The following is a description of a gene set: species: Mus musculus Mouse Gene Set: GOBP_DEVELOPMENTAL_PROCESS_INVOLVED_IN_REPRODUCTION A developmental process in which a progressive change in the state of some part of an organism, germline or somatic, specifically contributes to its ability to form offspring., and this is the list of marker genes: Pygo1, Dmrtc2, Amhr2, Zdbf2, Cetn2, Kdm3a, Lhb, Mgat4d, Armc12, Cfap119, Sun1, D1Pas1, Csmd1, Mir96, Ddx4, Jam2, Igf1, 3830403N18Rik, Dmc1, Safb2, Tnfaip6, Tex11, Shcbp1l, Txnrd3, Ccdc136, Airn, Nme5, Patz1 (NCBI Gene Id 80645), Cadm1, Abhd2, Mertk, Schip1, Marf1, Syne1, Kash5, Kat8, Septin6, Zfp628, Alkbh5, Wnt4, Zmynd15, Pafah1b1, Nanos1, Adam15, Mir34c, Myh9, Siah1a, Washc1, Cxcr4, Galnt3 (NCBI Gene Id 620893), Pdilt, Adam4, Spo11, Dnmt3b, Tsix, Tgfbr1, Prdx4, Usp26, Catspere2, Tbc1d20, Ptgs2, Acrbp, Tpgs1, Prss42, Dach1, Adam24, Chd5, Axl, Adam6a, Gli1, Aff4, Rbmyf9, Sprr2d, Junb (NCBI Gene Id 16477), Ldoc1 (NCBI Gene Id 434784), Prlr (NCBI Gene Id 19117), Npr2, Fkbp6, Ar, Tcp11, Tbata, Cyp19a1, Wdr19, H19, Bbs2, Adamts1, Gm1140, Mir124a-1hg, Irf2bpl, Stk4, Tmem119, Gata6, Btbd35f1, Dmrta2, Sass6, Tlr9, Nlrp14, Ccna1, Scmh1, Xlr4b, Slirp, Gjb2, Prkaca, Tesk2, Nanog, Spag6 (NCBI Gene Id 381350), Bbof1 (NCBI Gene Id 72873), Brip1, Cyp1b1, Parp11, Hfm1, Tmem203, Akap4, Foxa3, Rbx1-ps, Nek1, Adam18 (a disintegrin and metallopeptidase domain 18), Zar1l, Lhx9, Zmynd12, Adam32, Vegfa, Rps6ka2, Iftap (NCBI Gene Id 68170), Mas1, Ccdc87, Mir135a-2, Prss44, Col6a1, Pgam2, Pank2, Sgpl1, Abcb1a, Dmrta1, Tssk2, Mir471, Tspan8, Gdf7, Scx, Ptgis, Yif1b, Txndc2, Tiparp, Btg1, Lamp1, Pax5, A2m, Brme1, Gm20911, Svs3a, Wipf3, Nanos2, Fgfr2, Rec114, Hnf1a, Rad23b, Oosp2 (NCBI Gene Id 225922), Gm1993, Cd44, Cfap43, Src (NCBI Gene Id 99351), Rimbp3, Tsga8, Lhfpl2, Spata6l, Xrn2, Dzip1, Cylc1, Vipas39, Bltp1, Gata3, Sema3a, Spint2, Sirt2 (NCBI Gene Id 80489), Lgr5, Cit, Fbxo5, Gm10488, Nipbl, Tfpt, Oca2, Mns1, Gm28510, Plg, Spdya, Frey1, Cbl, Catsper3, Stau1 (NCBI Gene Id 99402), Ercc1, Slc26a8, Sstr2, Adcyap1r1, Sox17, Fgf9, Cftr, Rnase10, M1ap, Spocd1, Map3k4, Rxfp2, Ndp, Pou4f2, Hspa1l, Spata6, Asz1, Prm2, Cabyr, Tppp2, Calr3, Pcyt1b, Spatc1l, Agfg2, Stk33, Ddx25, Prss21, Fbxo24, Gm773, Bsph2, Prdx3, Brca2, Ddb1, Nphp1, Slit3, Mapk1, Tssk5, Nobox, Eomes, Ift20, Apob, Zfp830, Mroh2b, Gnas (NCBI Gene Id 78290), Cyp27b1, Tdrp, Iqcg, Eif2b5, Celf3, Gas2, Gtsf1, Gorasp2, Meioc (NCBI Gene Id 380729), Wnt9b, Racgap1, Slc9c1, C3, Bik (BCL2-interacting killer), Pten, Celf1, Rbmyf5, Ift27, Septin2, Hsf1, Ttll8, Figla, Garin2, Mir741, Txndc8, Cabcoco1, Ptx3, Slx, Mir878, Stat5a, Hoxd13, Tdrd5, Nell2, Inpp5b, Sulf1, Misfa, Tle6, Cfap61, Sf1, Cebpb, Piwil1, Adad1, Myocd, Hsf2, Acvr1, Prmt7, H1f6, Umodl1, Adam6b, Foxo3, Khdrbs1, Aurka, Clgn, Fem1b, Fancf, Poc1b, Foxa1, Nr2f2, Zfp41, Ezhip, Gm28870, Cntfr, Bmp4, Mdk, Atat1, Gk2, E2f8, Neurl4, Chtf18, Asmt, Mkks, Grk2, Pum1, Pde4d, Gm29866, Adam26b, Adam34l, Rnf151, Fgf8, Drc1, Strbp, Mamld1, Cep128, Kcne1, Ing2, Ttc12, Rhobtb3, Gm28102, Edn2, Trp53 (transformation related protein 53), Mkrn2, Ift25, Wt1, Sox8, Tlr3, Jag2, Gli3, Zfp35, Lgr4, Cnr1, Adam26a, Lrrc46, Unc5c, Tut7 (NCBI Gene Id 214564), Ctcf, Rnf2, Psma8 (NCBI Gene Id 73677), Sohlh2, Odf1, Rbmyf2, Cfap97d1, Srd5a1, Bmp5, Axdnd1, Fzd5, Csnk2a2, Fshb, Rarg, Hsf2bp, Six3, Vdac3, Scaper, Pde3a, Rsl1, Ct55, Sox9, Sox3, Tmf1, Dcaf13, Senp2, Hnrnpk, Eaf2, Bnc1, Fanca, Kit, Osbp2, Ccnyl1, Bcas2, Akap9, Mir138-2, Mir743, Bckdk, Cfap44, Zfp39, Garin4, Tial1, Mir184, Jam3, Cited2, Ccnb1ip1, Casp4, Nr0b1, Arrb1, Eif4g3, Meig1, Cdc25c, Srd5a2, Tdrd9, Rbp4, Nkapl, Tbc1d21, Mettl14, Cfap157, Slc22a14, Lhx8, Dlec1, Tssk6, Ncoa3, Mael, Eif2s2, Mycn, Lztfl1, Rab1a (RAB1A, member RAS oncogene family), Cnot7, Cfap52, Tmem184a, Cimap1a, Adam34, Ccr6, Gopc, Pafah1b3, Gm6121, Ndn, Klc3, Gm17266, Oog1, Actl9, Garin5b, Bak1, Zfp42, Cfap53, Tmprss12, Dnajb6, Prkg1, Gjb5, Prnd, Cnbd2, Eed, Paqr5, Ihh, Mir449b, Sox2, Cabs1, Gata4, Sycp3, Pafah1b2, Ybx2 (NCBI Gene Id 53422), Eqtn, Krt8, Tesc, Stc1, Inha, Plaur, Tgfb2, Ehmt2, Eif2s3y, Nup107, Ift56, Phb1, Herpud2, Cdyl, Cd2ap, Cdh1, Rnf114, Xist, Adam21, Cfap69, Gm2030, Fgf7, Septin4, Ctsb, Spata19, Slc22a5, Ggn, Yy1, Prm1, Adam2, Shbg, Mdfi, Id4, 2610005L07Rik, Rhox5, Dmrtb1, Ddx20, Ereg, Gm21627, Ssh2, Pde5a, Errfi1, Bscl2, Stxbp1, Slc4a2, Mfn2, AU040320, Rpl39l, Styx, 4930447C04Rik, Mycbpap, Pmfbp1, Tex15, Kdm2b, Bmp8a, Mir138-1, Mapk3, Trim28, Catsper4, Hspa2, Arrb2, Tbpl1, Ropn1l, Svs3b, Plag1, Foxc1, Defb37, Spinkl, Mir672, Washc5, Eif2b2, Tex19.1, Tdrd6, Ttll5, Rrm1, Rgn, Notch1, Ap3b1, Med1, Cxcl12, Pacrg, Angpt1, Kmt2d, Defb1, Bmpr2, Adad2, Gm20824, Inhbb, Cep131, Ttll1, Ghrl, Slc25a31, Catsperd, Rln1, Bmpr1b, Insrr, Sox15, Zpbp2, Shh, Arrdc5, H2al2a, Rnase9, Sbf1, Gm20820, Stc2, Gm4297, Mybl1, Spag17, Cfap58, Cfap65, Tssk1, Tcp11x2, Catsperz, Crkl, Plcb1, Serpinb6a, Cfap57, Dnali1, Stk11, Trip13, Ndrg3, Armc2, Rbx1, Cfap221, Smchd1, Calr, Iqcf1, Ift88, Slxl1, Gm5935, Mcmdc2, Rbmyf6, Tdrd7, Sirt1 (NCBI Gene Id 93759), Rbmyf1, Spink1, Usp42, Fhad1, Zfp57, St14, Pik3ca, Fshr, Ctsl, Herc2, Pnldc1, Sfrp1, Ccdc34, Arid5b, Zc3h14, Atn1, Hormad1 (NCBI Gene Id 67981), Btbd18, Gm2012, Zscan2, Xlr4c, Il1a, Septin7, Psme4, Dnhd1, Tcf23, Gm29554, Mmp19, Ascl2, Cfap54, Larp7, Ccdc63, Atrx, Cldn11, Ntrk1, Tdrkh, Smad4, Gamt, Mir183, Bcl2l1, Gm5934, Ttc21a, Adam1b, Dedd, Nup210l, Lep, Serpinb5, Pfn4, Msh2 (mutS homolog 2), Serpina5, Spag4, Bok, Mta2, Plekha1, Gm4787, Atm, Kdm1b, Paip2, Rara, Ovol1, Ppard, Cfap91, Vps13b, Tdrd12, Hnf4a, Nr5a1, Adamts2, Dhx36, Rbm46, Frs2, Aspm, Krt9, Eif2b4, Hsd17b4 (hydroxysteroid (17-beta) dehydrogenase 4), Cyp51, Mmp2, Sdc1, Zpbp, Bcl2, Tug1, Stk3, B4galt1, Idh1, Paqr8, Ubr2, Hoxa9, Angpt2, Xlr5b, Rbmyf8, Spata32, Flna, Piwil2, Morc1, Xlr3c, Gm38999, Nectin2, Fmn2, Golga3 (NCBI Gene Id 71391), Spmip7, Mir449a, Itgav, Hesx1, Gpr149 (NCBI Gene Id 229357), Six5, Pla2g4a, Mei1, Parp2, Esr1, Tcf7l2, Dhh, Rfx2, Rnf17, Msh4, Catsperg2, Crem, Hoatz, Mov10l1, Zfp296, Spag8, Prdm1, Rgs2, Adam29, Cylc2, Gm28919, Dnaja1, Mir135a-1, Adam1a, Tppp3 (tubulin polymerization-promoting protein family member 3), Dach2, Serpine1, Nicol1, Xlr4a, Catsperb, Meiosin, H3f4, Spata25, Slc9a8, Gm20890, Tsnax, Zbtb16, Selenof, Tifab, Itih5, Cntrl, Slc26a6, Nupr1, Rad51c, Sry, Cts8, Mir449c, Slco4c1, Chn2, Prkdc, Dhcr24, Fsip1, H1f1 (NCBI Gene Id 80838), Phc2, Fbxw11, Ctnnb1, Shisa6, Ccdc62, Psapl1, Smad5, Mir455, Chd7, Insl6, Serpinf1, Atp2b4, Spef2 (NCBI Gene Id 320277), Gm10230, Rps6kb1, Wnt2b, Xlr3b, Icam1, Alpl (NCBI Gene Id 11647), Rad21l, Morn2, Odad3, Rxra, Drc7, Taf7l, Fzd4, Ren1, Sun5, Gm29276, Zglp1, Wnt5a (NCBI Gene Id 77565), Insr, Zfp541, Zp3, Mei4, Runx1, Adrm1, Cip2a, Shb, Klhl10, Adam30, Gm21865, Garin5a, Dnmt3a, Foxj2, Ros1, Fxr1, Prdm14, Tcf21, Phb2, Xlr5a, Lin28a, Sod1, Tcf7, Garin3, Bsph1, Mfsd14a, Cyp26b1, Rai14, Mir881, Ccdc33, Sppl2c, Nanos3, Nup62, Fsip2, Hmga2, Ccdc38, Stat5b, Slc19a2, Casp2 (NCBI Gene Id 12366), Nkd1, Gm14525, Nos3, Sly, Sufu, Pdgfra, Pxt1, Xlr3a, Etv5, Ythdc1, Hps1, Gnasas1, Bmal1, Sec23ip, Npm2, Arid4b, Ptpn11, Star, Ptger4, Mir880, Cntln, Il1b, Ak7, Ppp1r9b, Cts7, Clock, Hadh, Nr6a1, Nsun2 (NCBI Gene Id 28114), Mir124-2hg, Izumo3, Calca, Ccdc42, Acvr2a, Fance, Pgr, Hmga1, Foxj3 (forkhead box J3), H2ax, Ropn1, Serpine2, Bcl6, Ctcfl, Spmap2, Edn1, Gm28576, Trp63, Csf1, Nefh, Gja1, Htt, Rhox8, Cbx2, Asb1, Lsm14b, Ube3a (NCBI Gene Id 76097), Pla2g3, Adam7, Foxf2, 1700102P08Rik, Vgf, Rbmyf7, Dmrt3, H3f3a, Kdr, Gdf9, Setx, Dcaf17, Tex19.2, Jmjd1c, Stau2, Zfy2, Ptprn, Foxl2, Sfrp2, Hmgb2, Epc1, Gm20736 (predicted gene, 20736), Cep57, Ube2j1, Tnp2, Ahr, Spmip6, Catsper2, Tesmin (NCBI Gene Id 17771), Adam39, Retn, Smad9, Cfap206, Katnal1, Crtap, Herc4, Rsph1, Tnk2, Alms1, Fancg, Gm21117, Ubb, Terb2, Rsph6a (NCBI Gene Id 83434), Pias1, Gm5168, H3f3b, Ptn, Cdkn1c, Ggnbp2, Afg2a, Ash1l, Igf1r (NCBI Gene Id 77773), Cdk16, Nrip1, Nhlh2, Tarbp2, Spaca1, Mmp14, Actl7a, Spag6l (NCBI Gene Id 50525), Fer, Xlr, Dnah1, Neurog1, Tyro3, Gm20817, Akt1, Fancc, Galntl5, Tsx, Mast2, Nos2, Hoxa13, Grb14, Lif, Ago4, Bmp6, Hyal3, Ndc1, Gfra1, Amh, Plk4, Dnajc19-ps, Tssk3, Ghsr, Fgf10, Apc, Spata22, Kiss1, Sox30, B4galnt1, Ppp2r1a, Msh6, Epor, Rxrb, Spata20, E2f7, Dmxl2, Bmp8b, Pax2, Esr2, Bcl2l11, Majin, Ccin, Iho1, Antxr2, Hoxa10, Adig, Tgfb1, Mtor, Ccdc159, Mst1, Zfp37 (NCBI Gene Id 22696), Mir34b, Garin1b, Nme8, Neurl1a, Hsf5, Mir193a, Spata2, Sohlh1, Snrpa1, Pdcl2 (phosducin-like 2), H2aj, Arid4a, Insl3, Lhcgr, Zfpm2, Sstr1, Bbs4, Tslrn1, Hnf1b, Tuba8, Adam25, Bax, Rhbdd1, Tmem232, Mir202, Nog, Iqcn, Gpx4, Zfp449, Rnf8, Nkx2-1, Inhba, Ednra, Adam20, Skil, Dld, Mettl3, Cox7b2, Kitl, Fndc3a, Lrguk, Topaz1, Spag16, Bag6, Kmt2b, Lrrc8a, Gm7958, Paqr7, Hoxb13, Gcm1, Meg3, Gm28961, Ccdc182, Zcwpw1, Ace, Cfap70, Fst, Lfng, Gm21858, Rpl10l, H1f7, Mecp2, Gsk3b, Qki, Slc26a3, Gli2, Catsper1, Il11ra1, Dazap1, Slc22a16, Gal3st1, Tm9sf5, Nkx3-1, Parp1, Grhl2, Hexb, Cyp7b1, Ccnb1, Six4, Fkbp4, Pld6, 1700013H16Rik, Pygo2, Dnd1, Map7, Mir144, Utp14b, Cntd1, Odf4, Rac1, Snai1, Zar1, Dmrt1, Ggt1, Gata1, Ncoa1, Elf5, Pkd1, Agt, Poc1a, Rb1, Stra6, Brdt, Lrrk2, Cga, Diaph2, Ube2b, Spata31, Adam5, Prm3, Dpcd, Smarcc1, Ythdc2, Tut4, Hectd1, Vps54, Pcsk4, Ppp1cc, Ica1l, Tdrd1, Ccnd1, S100a11, Gm5169, Cdkn1b, Irx5 (Iroquois homeobox 5), Lrp6, Boll, Nr2c2, Gsr, Psap, Spem3, Mir182, Afp, Gnrh1, Oas1d, Dicer1, Nppc, Lrp2, Cdc25b, Erf, Ahsg, Lrriq1, Acsbg2 (acyl-CoA synthetase bubblegum family member 2), Gm21996, Taf4b, Pithd1, Krt19, Rps6, Acox1, Bsg, Dlg1, Ror2, Tnfsf10, Casp3, Dazl, Hoxa11, Tesk1 (NCBI Gene Id 21754), Immp2l, Ybx3, Hook1, Gmcl1, Ddias, Gm20843, Sycp2, H2bc1, Creb3l4, Lhx1, Agfg1, Stox2, Ptgdr, Adgrg1, Adcyap1, Gm21294, Atp1a4, Fscn3, Rec8, Gmnc, Dnajc19, Tbx3, Gjb3, Mir742, Taf4, Spata9, Wee2, Gm20870, Pbx1, Dpy19l2, Gsk3a, Rbmy, Areg, Garin1a, Tnp1, Nudt1, Spem1, Ptch1 (patched 1), Tnc, Greb1l, Bmp7, Ttll3, Dhx37, Mea1, Nr5a2 (nuclear receptor subfamily 5, group A, member 2), Tlk2, Wdr48, Bcap31, Ift81, Sstr3, Pitx2, Sfmbt1, Tsnaxip1, Zscan21, Zfx, Kif18a, Rab13, Asb17, Igf2r, Syce3, Ccno, Cib1, Dnaaf11, Mlh1, Mos, Gm21095, Catspere1 (NCBI Gene Id 631584), Wdr77, Prdm9, Tmed2, Mcidas, Semg1, Tle3, Prss43, Dmrt2, Dnmt3l, H1f9, Fam209, Sebox, Spata24, Gm21760, Septin14, Adam3, C2cd6, Tssk4, Efcab9, Adgb, Sycp1, Vdr, Rbmyf3, Xlr5c (X-linked lymphocyte-regulated 5C), Adcy10, Ccdc146, Limk2, Spata46, Prok2, Rad18, Pgm3, Ggnbp1, Rdh10, Kdm5b, Kcnq1ot1, Kdm5a, Stra8, Osr1, Kat5, Cfap47, Pabpc1l (poly(A) binding protein, cytoplasmic 1-like), Ythdf2, Bmpr1a, Dnaaf3, Upf3a, Pln, Ctnna1, Odf2, Piwil4, Hand1, Ermp1, Spink2, Nodal, Armc3, Ptk2b, Bcl2l2, Ankrd49, Pebp1, Spata16, Wnt7a (wingless-type MMTV integration site family, member 7A), Cul4a